Given this list of marker genes Gpr27, Bmp6, Cxcl14, Scrt1, Slc12a5, Chat, Casz1, Oprd1, Hoxa13, Ryr2, Slc30a3, Gjd2, Eif4e3, Iqsec3, Car7, Notum, Cbln4, Sim2, Kcns2, Sall4, Igf2, Chrna4, Foxq1, Gja3, Bnc1, Pax3, Onecut3, Ucn, Pax1, Pld5, Gata6, Gm7276, Lama1, Penk, Scn5a, Dmbx1, Bicdl1, Hrh3, Calcr, Rbfox3, Foxf1, Ptprt, Stum, Kcnh1, Hmx1, Actl6b, Clcf1, Slc18a3, Galr3, Cpeb1, Hr, Celsr1, T, Shisa6, Stxbp2, Kcnq2, Kcns3, Dnah11, Tmem163, Bmp8a, Bnc2, Rap1gap2, Dscam, Foxe1, Lrrc26, Tlx2, Fam78a, Crtac1, Hmx3, Sgpp2, Srcin1, Foxb2, Hoxd13, Xkr7, Tbx21, Jag2, Ocln, Amer3, Prok2, St8sia6, Ecel1, Scube3, Ly6h, Atp6v1c2, Evx1, Lmx1a, Utf1, Prph, Tbx3, Mroh5, Spint1, Pax2, Msx2, Hmx2, Phf24, Rgs6, Ankrd63, Gsx1, Cimip3, Cited4, Nfatc2, Clgn, C1ql1, Syndig1l, Rtn4r, Egflam (EGF-like, fibronectin type III and laminin G domains), Dok4, Fgf8, Rerg, Oaf, Sim1, Cadps, Igsf21, Gjb2, Dmrt3, Rasgef1c, Pard6b, Pitx1, Fam89a (family with sequence similarity 89, member A), Sult4a1, Abcg1, Syne3, Alk, Msx3, Rab11fip1, Smoc2, Gabrb1, Ptprn2, Tmem150c, Rab11fip4 (NCBI Gene Id 319892), Podn, Ccdc92b, Dmrt2, Igfbpl1, Sfrp1, Stxbp5l, Map3k21, Wnt6, Kcna1, Fibcd1, Slc6a17, Ahnak, Hcn2, Ptgfrn, A330008L17Rik, Cdh1, Agpat2, Vwa2, Fgf3, Nkx2-1, C1ql2, Ikzf3, Arid3c, Rprml, Col13a1, Stac2, Sorcs3, Vat1l, Paqr9, Zfp536, Sox18, Cryba2, Gabra5, Sntg1, Slco4c1, Neurod2, Nkx6-1, Cacna2d2, Foxd4, Slc22a3, Wnt4, Pou4f3, Ltbp2, Aff3, Dact2, Ankrd34b, Tgfb1, Prdm6, Nalf2, Kcna7, Fli1, Tesc, Hcn1, Cacna1i, Xkr4 (NCBI Gene Id 497097), Ralyl, Pgbd5, Dock8, Myrip, Nog, Ovol1, Wnt1, Gabbr2, Nkx2-4, Cnnm1, Crabp1, Lemd1, Lad1, Gdnf, Zfp296, Stx3, Syt2, Tmem132e, Cdh11, Ptf1a, Grik3, Wnt9b, Lbx1, Sptbn2, Six2, Prdm16, Kcnk1, Phlda2, Ahr, Kcnk3, Dlx3, Scube1, Gng4, Emx1, Gjd3, Syt12, Vax1, Dpp10, Wnt9a, Prmt8, Helt, Galnt14, Trp73, Nptxr, Hrk (harakiri, BCL2 interacting protein (contains only BH3 domain)), Adamts2, Nefh, Kcng3, D930020B18Rik, P4ha2, Pth2, Cadm3, Kcnc4, Lhx8, Flt3 (NCBI Gene Id 269731), Sowahb, Hoxd11, Foxg1, Cyp26a1, Kirrel2, Cdk5r2, Syt14, Adra2c, Ghsr, Irf5, Npr3, Hoxc5, Baiap2l1, Nxph3, Pappa, Foxd3 (NCBI Gene Id 15221), Fam43b, Insm2, Ihh, Tlx1, Vipr1, Foxf2, Unc5d, Cntn2 (NCBI Gene Id 320300, contactin 2), Kcnh8, Msc, Kcnk12, Cadps2, Slc26a4, Eva1a, Atp2b2, Ovol2, Ret, Ffar4, B3gnt7, Rasgrf1, Cobl, Slc30a10, Colec12, Mast1, Aldh1a2, Slc9a2, Dlx5, Wnt3a, Spire2, Vgll2, Fam163b, Cabp7, Kcna3, Cpne5, Gabrg3, Lhx6, Clstn2, Mmp24, Scn4b, Gbx1, Acan, Pdgfb, Tlx3, Tbx1, Bik, Tdrp, Cdh8, Hs3st6, Wscd2, Cplx1, Serinc2, Sema7a (sema domain, immunoglobulin domain (Ig), and GPI membrane anchor, (semaphorin) 7A), Sp8, Plppr3, Htr7, Ptger3, Trnp1, Tcf15, Ppp2r2c, Itga3, Npas1, Mal, Gnas, Foxc2, Ascl2, Amigo2, Nalf1, A4galt, Stbd1 (starch binding domain 1), Fev, Prokr2, Dbx1 (developing brain homeobox 1), Adgrb1, Atp2b3, Hoxd1, Tmem151a, Elavl3, Galnt13, Crhr1, Gata2, Plk5, Mafa, Dlgap2, Jph3, St6gal2, Isl1, Foxe3, Npas2, Pou4f2, Rspo1, Vsx1, Dscaml1, Fbll1, Kctd8, Prr16, Uncx, Hcrtr1, Mcidas, here is a description of the gene set: DNA methylation is essential for normal development and has been implicated in many pathologies including cancer. Our knowledge about the genome-wide distribution of DNA methylation, how it changes during cellular differentiation and how it relates to histone methylation and other chromatin modifications in mammals remains limited. Here we report the generation and analysis of genome-scale DNA methylation profiles at nucleotide resolution in mammalian cells. Using high-throughput reduced representation bisulphite sequencing and single-molecule-based sequencing, we generated DNA methylation maps covering most CpG islands, and a representative sampling of conserved non-coding elements, transposons and other genomic features, for mouse embryonic stem cells, embryonic-stem-cell-derived and primary neural cells, and eight other primary tissues. Several key findings emerge from the data. First, DNA methylation patterns are better correlated with histone methylation patterns than with the underlying genome sequence context. Second, methylation of CpGs are dynamic epigenetic marks that undergo extensive changes during cellular differentiation, particularly in regulatory regions outside of core promoters. Third, analysis of embryonic-stem-cell-derived and primary cells reveals that 'weak' CpG islands associated with a specific set of developmentally regulated genes undergo aberrant hypermethylation during extended proliferation in vitro, in a pattern reminiscent of that reported in some primary tumours. More generally, the results establish reduced representation bisulphite sequencing as a powerful technology for epigenetic profiling of cell populations relevant to developmental biology, cancer and regenerative medicine. studied in species Mus musculus from publication Meissner A, Mikkelsen TS, Gu H, Wernig M, Hanna J, Sivachenko A, Zhang X, Bernstein BE, Nusbaum C, Jaffe DB, Gnirke A, Jaenisch R, Lander ES (PMID 18600261) Genes with high-CpG-density promoters (HCP) bearing histone H3 dimethylation mark at K4 (H3K4me2) and trimethylation mark at K27 (H3K27me3) in neural precursor cells (NPC). Mouse Gene Set: MEISSNER_NPC_HCP_WITH_H3K4ME2_AND_H3K27ME3